Given this list of marker genes Pip5k1c, Islr2, Knop1, Csnk1g1, Gimap8, Alg11, Septin8, Ube2k, Slc6a7, Chid1, Zfx, Vipas39, here is a description of the gene set: from publication Xie S, Zhou N, Su N, Xiao Z, Wei S, Yang Y, Liu J, Li W, Zhang B (PMID 38577019) Mouse Gene Set: XIE_TRASTUZUMAB_CARDIOTOXICITY_MMU_MIR_193A_3P_GENES studied in species Mus musculus Abstract: Trastuzumab-induced cardiotoxicity (TIC) is a common and serious disease with abnormal cardiac function. Accumulating evidence has indicated certain non-coding RNAs (ncRNAs), functioning as competing endogenous RNAs (ceRNAs), impacting the progression of cardiovascular diseases. Nonetheless, the specific involvement of ncRNA-mediated ceRNA regulatory mechanisms in TIC remains elusive. The present research aims to comprehensively investigate changes in the expressions of all ncRNA using whole-transcriptome RNA sequencing. The sequencing analysis unveiled significant dysregulation, identifying a total of 43 circular RNAs (circRNAs), 270 long noncoding RNAs (lncRNAs), 12 microRNAs (miRNAs), and 4131 mRNAs in trastuzumab-treated mouse hearts. Subsequently, circRNA-based ceRNA networks consisting of 82 nodes and 91 edges, as well as lncRNA-based ceRNA networks comprising 111 nodes and 112 edges, were constructed. Using the CytoNCA plugin, pivotal genes - miR-31-5p and miR-644-5p - were identified within these networks, exhibiting potential relevance in TIC treatment. Additionally, KEGG and GO analyses were conducted to explore the functional pathways associated with the genes within the ceRNA networks. The outcomes of the predicted ceRNAs and bioinformatics analyses elucidated the plausible involvement of ncRNAs in TIC pathogenesis. This insight contributes to a better understanding of underlying mechanisms and aids in identifying promising targets for effective prevention and treatment strategies.